The following is a description of a gene set: Genes up-regulated in CD4 SMARTA effector T cells during acute infection of LCMV: Th1 versus follicular helper (Tfh). from publication Hale JS, Youngblood B, Latner DR, Mohammed AU, Ye L, Akondy RS, Wu T, Iyer SS, Ahmed R (PMID 23583644) studied in species Homo sapiens CD4 T follicular helper (Tfh) cells provide the required signals to B cells for germinal center reactions that are necessary for longlived antibody responses. However, it remains unclear whether there are CD4+ memory T cells committed to the Tfh lineage after antigen clearance. Using adoptive transfer of antigen-specific memory CD4+ subpopulations (based on CXCR5 and Ly6c expression)in the LCMV infection model, we found that there are distinct memory CD4+ T cell populations with commitment to the Tfh and Th1 lineages. Our conclusions are based on gene expression profiles, epigenetic studies and phenotypic and functional analysis. The gene expression profiles of virus-specific CD4 T cell subets at effector and memory stages is presented here. Human Gene Set: GSE43863_TH1_VS_TFH_EFFECTOR_CD4_TCELL_UP, and this is the list of marker genes: DAGLB, OTOP1, GLS, C3 (complement component 3), PHIP, JTB, SUCNR1, TMEFF2, BICD1, SLC38A4, SPINK4, SERINC5, TRIM17, GOLM2, KIF20B, OMP, XCR1, NUP153, SEMA6B (NCBI Gene Id 56991), NFATC4, SNCAIP, ELL, PPP2R5B, CST5, EDEM1, KRT85, INF2, P2RX3, RPAP3, TRIM72, STAC, MVD, SNX6, IGFBP2, FPGS, LATS2, PLGRKT, PROB1, PAMR1, RPS6KA5, AKAP14, PARM1, CLXN, JMJD7-PLA2G4B, PCDH8, KRT14, LNX1, GJB4, KCNJ2, DENND1B, GJA4, ADHFE1, RBM14, LIPK, PCGF2, NPY4R, CES3, CCDC117, UBXN1, MEIOB (NCBI Gene Id 254528), LRFN2, GIMAP6, ACTB, WNK1, PTPN5, CIMIP2A, EML3, CBLN3, LRRC58, SOX18, RNF2, ATP13A2, AATK, DENND2B, FAM120C, LYPD1, DCST1, SDC1, GOT1L1, PPL (NCBI Gene Id 5493), COL3A1, PSMD14, UPF3B, GLT8D1, RASIP1, SHISA5, ARL10, ARL13A, SPRR2A, B3GNT8, MMP20, TMEM151A, RIOK3, TMEFF1, FLRT3, GALNT3, GPR39, PHETA2 (PH domain containing endocytic trafficking adaptor 2), MIA, SNAPC1, LRRC66, AMHR2, LCA5, SLITRK6, C6orf141, DCC, OPRM1, WNT3, ARSJ, ALOXE3, NKX6-2, DPP4, SLC5A11, XPO7, GCNT3, FCHO2, FOXS1, CTNNA2, CD207, RSRC1 (NCBI Gene Id 51319), FAR1, CYP24A1, ENSA, NBEAL1, MCL1, ACER2, XIAP, GJC2, MAGED1, C3orf52, ZSWIM2, HOXA11 (homeobox A11), SNX21, MIER1, ZNF334, VLDLR, CHRNA9, ASAH2, FBXO41, WDR6, EXOC2, MAN2A1, C16orf96, SEMA3E, NTNG1, OPCML, RPUSD1, CILP, TBC1D12, BTD, SLC39A1, ALDH3A1 (aldehyde dehydrogenase 3 family member A1), RNF121, FAM170B (NCBI Gene Id 399567), RGR, HPSE, ACBD5, IQCF1, APBA3, ST7, LRRN1 (leucine rich repeat neuronal 1), IGSF8, FSTL1, SND1, RHOJ, EFNA5, TTC14, ILDR1, MAP2 (NCBI Gene Id 4133), MEOX1 (mesenchyme homeobox 1), C2orf80, WDR82, SPDEF, CNBD2, ACTN2, ORMDL3, QKI, TRDN, FMR1NB, ZNF536, RGMA, KHNYN, SH2B3, PLAA, ANKRD1 (NCBI Gene Id 27063), INHBB, NOL3, COG5, TPSG1, B2M, DLGAP1, CCER1, ASPDH, PBLD, NIPSNAP3B (NCBI Gene Id 55335), YIPF2, SPP2, TRIM62, PHLPP2, ZBTB43